Given this list of marker genes STEAP2-AS1, FKBP1A, H2AC7, FOXO4, CBFA2T3, CYP11B1, ENTPD1, PCDH9, ABTB2, ADGRB2, TGM2 (transglutaminase 2), NRG1, APEX2, PSPHP1, here is a description of the gene set: species: Homo sapiens Neurovascular dysfunction substantially contributes to Alzheimer disease. Here, we show that transcriptional profiling of human brain endothelial cells (BECs) defines a subset of genes whose expression is age-independent but is considerably altered in Alzheimer disease, including the homeobox gene MEOX2 (also known as GAX), a regulator of vascular differentiation, whose expression is low in Alzheimer disease. By using viral-mediated MEOX2 gene silencing and transfer, we show that restoring expression of the protein it encodes, GAX, in BECs from individuals with Alzheimer disease stimulates angiogenesis, transcriptionally suppresses AFX1 forkhead transcription factor-mediated apoptosis and increases the levels of a major amyloid-beta peptide (Abeta) clearance receptor, the low-density lipoprotein receptor-related protein 1 (LRP), at the blood-brain barrier. In mice, deletion of Meox2 (also known as Gax) results in reductions in brain capillary density and resting cerebral blood flow, loss of the angiogenic response to hypoxia in the brain and an impaired Abeta efflux from brain caused by reduced LRP levels. The link of MEOX2 to neurovascular dysfunction in Alzheimer disease provides new mechanistic and therapeutic insights into this illness. Human Gene Set: WU_ALZHEIMER_DISEASE_UP from publication Wu Z, Guo H, Chow N, Sallstrom J, Bell RD, Deane R, Brooks AI, Kanagala S, Rubio A, Sagare A, Liu D, Li F, Armstrong D, Gasiewicz T, Zidovetzki R, Song X, Hofman F, Zlokovic BV (PMID 16116430) Genes up-regulated in brain endothelial cells from patients with Alzheimer disease.